Given this list of marker genes HSPBAP1, PRKDC, CLCN3, GPBP1L1, NPRL2, WIPI2, B3GNT2, MAPKBP1, EIF4B, ODAD1, CTSC, ELOVL5, TMEM42, YPEL2, MAP4K1, DMXL2, LETMD1, GATB, ASH1L, PPP6R2, H6PD, BCKDHB, TMEM63A, MRI1, VPS39, TCF7, MRPL40, FAM53B, FAAH, FAM8A1, CTDSPL2, COMMD2, RAB3GAP2, GLUD1, SPRR4, FAM174B, DUSP7, GYS1, HSF4, TEX9, EVA1B, LANCL1, CUL3, ARL11, HDAC10, SDR39U1, CASP7, JMJD4, CYB5R1, PPT2, PTK2B, CAPN1, ENTPD5, TMEM120A, TMEM104, PDCD6IP, KAT2B (NCBI Gene Id 8850), RGS14, RO60, TMEM60, SLCO4C1, PODNL1, SAMD3, PSKH1, BTBD19, ZMYND11 (NCBI Gene Id 10771), WDR26, TUBGCP2, OTULINL, BCS1L, NTAQ1, FNIP2, HS1BP3, RNPEPL1, COBLL1, UNKL, IDUA (alpha-L-iduronidase), CTSW, PTGER2, PYM1, PI4KB, ABCB10, SLC11A2, MIEF2, PIGX, MYO18A, UBE4A, ABTB1, LINC-PINT, CHRNB1 (cholinergic receptor nicotinic beta 1 subunit), SLC41A3, RMND5A, FMO5, CCNG1, NDUFAF1, CFL1, HIP1, RGP1, MLF2, WDR83, S100A1, ICOS, PHETA2 (NCBI Gene Id 150368), ZDHHC18 (zinc finger DHHC-type palmitoyltransferase 18), KIF16B, MLEC, HYCC2, GPR132, CSTB, CHD9, TMEM161A, EEFSEC, PHKB, RBM38, PRKAG2, SMARCAL1, PJA2, MED24, IKZF5, TUBGCP6, PGAP6, PI4KA, PADI2, TSNAX, STARD10, GALNT12, ZFTRAF1 (NCBI Gene Id 50626), NDFIP1, MPRIP, GATD1, PIGK, TBCD, MOB3A, RAB4A, GRHPR, TRAPPC12, PFKFB4, STIM1, ANXA7, KLF12, CC2D1A, BCL7A, PLCB3, FOXO4, ZBTB33, AFG1L, VAPB, WDFY2, NDUFV1, ACSS2, CALM1, TAOK3 (NCBI Gene Id 51347), KRT80, MPV17L, YWHAQ, RNF24, TRAF3IP2, MAVS, here is a description of the gene set: from publication Cipolletta D, Feuerer M, Li A, Kamei N, Lee J, Shoelson SE, Benoist C, Mathis D (PMID 22722857) We identified Pparg as a major orchestrator of the phenotype of adipose-tissue resident regulatory T cells (VAT Tregs). To explore the contribution of Pparg1 and 2 in the generation of the VAT Tregs-specific gene signatures, CD4+FoxP3- T cells were transduced with Foxp3+/- Pparg1 (or Pparg2), treated with Pioglitazone or vehicle, and double sorted for microarray analysis. Genes down-regulated in CD4 T cells over-expressing FOXP3 and Pparg2 isoform of PPARG: untreated versus pioglitazone. studied in species Homo sapiens Human Gene Set: GSE37533_UNTREATED_VS_PIOGLIZATONE_TREATED_CD4_TCELL_PPARG2_AND_FOXP3_TRASDUCED_DN